The following is a description of a gene set: Any process that stops, prevents or reduces the frequency, rate or extent of execution phase of apoptosis. Human Gene Set: GOBP_NEGATIVE_REGULATION_OF_EXECUTION_PHASE_OF_APOPTOSIS studied in species Homo sapiens, and this is the list of marker genes: DFFA, CIDEA, GCG, MIR30B, MIRLET7B, BCL2L1, FZD3, CXCR3, HSPD1